The following is a description of a gene set: Genes having at least one occurence of the motif ACCGAGC in their 3' untranslated region. The motif represents putative target (that is, seed match) of human mature miRNA hsa-miR-423 (v7.1 miRBase). species: Homo sapiens Human Gene Set: ACCGAGC_MIR423, and this is the list of marker genes: CDK10, FGFR2, PABPC1, PABPC3, HIC2, RAP2C, DLGAP1 (DLG associated protein 1), BCORL1